Given this list of marker genes HAND2, SMARCD3, TBX5, NOTCH1 (NCBI Gene Id 54781), HAND1, MEF2C (NCBI Gene Id 4208), MESP1, NKX2-5, here is a description of the gene set: Human Gene Set: GOBP_CARDIAC_VENTRICLE_FORMATION species: Homo sapiens The developmental process pertaining to the initial formation of a cardiac ventricle from unspecified parts. A cardiac ventricle receives blood from a cardiac atrium and pumps it out of the heart.